Given this list of marker genes Csmd2, Arf6, Dgkz, Mpp2, Dlg2, Shank3, Shank1, Dlg1, Prickle1, Prickle2, here is a description of the gene set: A process which maintains the organization and the arrangement of proteins in the presynaptic density. Mouse Gene Set: GOBP_MAINTENANCE_OF_POSTSYNAPTIC_DENSITY_STRUCTURE species: Mus musculus